The following is a description of a gene set: Human Gene Set: HP_SEX_REVERSAL Development of the reproductive system is inconsistent with the chromosomal sex. species: Homo sapiens Sex reversal, and this is the list of marker genes: MAP3K1, DHH, SOX9, NR5A1, RSPO1, WNT4, AKR1C4, AKR1C2, NR0B1 (NCBI Gene Id 8238), CBX2, ZFPM2, CILK1, SRY, CYP11A1